The following is a description of a gene set: Human Gene Set: GNF2_KPNB1 studied in species Homo sapiens Neighborhood of KPNB1 karyopherin (importin) beta 1 in the GNF2 expression compendium Neighborhood of KPNB1, and this is the list of marker genes: RTRAF, PPIH, HDAC1, KPNB1, ZBTB1, SRSF10, AIMP1, SSBP1, PRPF31, NOL11, U2SURP, SYNCRIP, PRPF40A, HNRNPU, CEP57, HNRNPR, OARD1, PDS5A, ZC3H15, RBMX, SUZ12, KHDRBS1, PSMA1, IFT25, BUB3, PABPN1 (poly(A) binding protein nuclear 1), NOP14, NCL, TPR, DDX47, HNRNPF, COPS2, SMARCA5, CNOT7, SRSF3, USP1, TOPBP1, DARS1, RNF138, EED, TARDBP, UQCRC2, CPSF6, EXOSC8, DDX18, NOC3L, SRSF1, NUP153, DHX15, PUM3, LAS1L, SNRPD3, NAE1, MAGOH, SNRPE, FBL, TSN, SMC3, ELAC2, HNRNPK, SRSF7, HNRNPM, SF3B2, SFPQ, PSIP1 (NCBI Gene Id 93428), EIF3D, SNRNP200, XRCC5, MAP3K4 (mitogen-activated protein kinase kinase kinase 4), SRP54, SKIC8, HNRNPA3P1, NAA15